The following is a description of a gene set: studied in species Homo sapiens Human Gene Set: HP_ABNORMAL_SUBCLAVIAN_ARTERY_MORPHOLOGY Any anomaly of a subclavian artery. Abnormal subclavian artery morphology, and this is the list of marker genes: TBX1, PIK3CD, PLD1 (NCBI Gene Id 5337, phospholipase D1), TGFBR2, PLXND1, NKX2-6, CREBBP, DDX6, KNSTRN, ACTA2 (actin alpha 2, smooth muscle), EP300